The following is a description of a gene set: studied in species Mus musculus Cytokines mediate cell-cell communication in the immune system and represent important therapeutic targets. A myriad of studies have highlighted their central role in immune function, yet we lack a global view of the cellular responses of each immune cell type to each cytokine. To address this gap, the authors created the Immune Dictionary, a compendium of single-cell transcriptomic profiles of more than 17 immune cell types in response to each of 86 cytokines (>1,400 cytokine-cell type combinations) in mouse lymph nodes in vivo. A cytokine-centric view of the dictionary revealed that most cytokines induce highly cell-type-specific responses. For example, the inflammatory cytokine interleukin-1β induces distinct gene programmes in almost every cell type. A cell-type-centric view of the dictionary identified more than 66 cytokine-driven cellular polarization states across immune cell types, including previously uncharacterized states such as an interleukin-18-induced polyfunctional natural killer cell state. from publication Cui A, Huang T, Li S, Ma A, Pérez JL, Sander C, Keskin DB, Wu CJ, Fraenkel E, Hacohen N (PMID 38057668) Genes positively differentially expressed in cell type: CD8+ T cell upon treatment with cytokine: IL-4 in mouse lymph nodes in vivo. Mouse Gene Set: CUI_T_CELL_CD8_IL4_RESPONSE_UP, and this is the list of marker genes: Phb1 (NCBI Gene Id 18673), Hnrnpu, Gadd45gip1 (growth arrest and DNA-damage-inducible, gamma interacting protein 1), Ddx21, Abcf1, Fkbp4, Eif1a, H2-DMa, Ybx3, Sdad1, Uqcrb, Psma2, Hdgf, Hspe1, Adh5, St6galnac4, Esf1, Nolc1, Ifrd2, Ndufab1, Mrpl42, Pum3, Ncl, Nhp2, Mrps18b, Fam162a, Eprs1 (NCBI Gene Id 96892), Pfn1 (NCBI Gene Id 18643), Anp32b, Bzw2, Cnbp, Rsl1d1, Arid5a, Gars1, Adk, Hspa9, Slc25a5, Hspbp1, Ssb, Myc, Mia2, Gnl3, Mif, Eif3j1, Them6, Lyar, Cox7b, Tkt, Nop56, H2az1, Mrps28, Psme2, Mdn1, Ruvbl2, Rexo2, Pdap1, Ncoa7, Fubp1, Cst7, Cacybp, Nifk, Rbmxl1, Mrpl36, Gart, Prdx1, Lsm4, Foxn3, Pop5, Uqcc5, Taf10, Tmem147, Cct3, Znrd2, Cyth1, Znhit6, Slc29a1, Rnf19b, Sec11c, Impdh2 (inosine monophosphate dehydrogenase 2), Ncoa3, Ppa1, Cct5, Clic4, Tpi1, Slfn1, Syncrip, Prpf31, Tmie, Pfdn6, Atp5mc1, Ifi47, S100a13, Phgdh (NCBI Gene Id 50895), Mphosph10, Psmb10, Ybx1, Atp5f1b, Mrpl20, Mrpl51, Wdr83os, Lsm12, Glrx5, Timm10, Lap3 (leucine aminopeptidase 3), Aldh18a1, Psmc5, Rcc2, Timm13, Eif4a1, Mrpl15, Phb2, Mdh2, Utp18, Mettl1, Rrp9, Mrpl57, Npm3, Ndufs6, Nars1, Rmi2, Snhg6, Mrpl12, Dusp10, Atad3a, Ndufb4, Erh, Gtpbp4, Ppat, Snrpd1, Aimp2, Park7, Slc7a1, Elf1, Sco2, Hnrnpd, Ppan, Alkbh1, Mrps14, Tcp1, Cdk6, Snrpa, Hmgb1, Hsp90ab1, Elob, Ak2, Stat4, Ltv1, Rras2, Eif3a, Tomm40, Ppp3cc, Bcl2, Wdr43, Atp5mk, Nop14, Cdca7l, Nudc, Serbp1, Otulin, Plac8, Mybbp1a, Mbd2, Ddx18, Chchd1, Lars1, Apex1, Zfp593, Ggact, Psat1, Ifi35, Hnrnpab, Exosc8, Banf1, Ftsj3, Ldha, Psma7, Grwd1, Lsm8, Rpf2, Wdr12, Uqcr10, Oxct1, Shmt2, Dnaja2, Hsd11b1 (hydroxysteroid 11-beta dehydrogenase 1), Pa2g4, Snu13, Cycs, Rwdd1, Ndufa12, Hnrnpr, Npm1, Cct2, Pebp1, Erap1, Il4ra, Hsp90aa1, Tma16, Lsm6, Pla2g12a, Mrps24, Gpatch4 (NCBI Gene Id 66614), Atp5mc3, Bysl, Cxcr6, Polr2f, Cyc1, Cnp, Eef1e1, Uqcrq, Psmb5, Tcof1, Mri1, Mthfd1, Nip7, Lyst (lysosomal trafficking regulator), Ssrp1, Cyfip2, Jaml, Pfkp, Arpp19, Galk1, Sars1, Timm50, Gzma (NCBI Gene Id 14938), Yars1, Als2cl, Cox17, Snrpa1, Ppp1r14b, Nme1, Cd8a, Tuba1b, Eif4ebp1, Socs1, Vdac2, Agfg1, Ddx27, Dkc1, Eif1ax, Srsf2, Srm, Ndufs4, Slco3a1, Psmg4, Polr2h, Eif2s2, Cct7, Hs6st1, Bst2, Npepl1, Tspan9, Txn1, Aprt, Uqcc2, Set, Tomm5, Hspa4, Aatf, Cdca7, Lsm7, Qdpr, Txn2, Mrpl19, Ruvbl1, Timm8a1, Ndufb7, Psme1, Ptma, Eif2s1, Tuba4a, Snrpb, Llph, Pole4, Suz12, Polr1g, Glipr2, Eif5a, Tpm3, Ndufa5, Mars1, Noc2l, Xbp1, G3bp1, Nop58, Vars1, Timm10b, Pfdn2, Ran, Hspa5, Ranbp1, Mak16, Tomm20, Dnajc2, Fabp5, Fbl, Ddx39a, Nop2, Snrpf, Iars1, Gapdh, Cct8, Atic, Vapa, Emc6, Nubp1, Aars1, Eomes, Nsun2, Rgs1, Cdk4, Denr, Nptn, Ucp2, Eif4a3, Cox5a, Inpp4b, Eif3c, Hspd1, Cox6a1, U2af1, Mrpl17, Ebna1bp2, Ndufaf4, Suclg2, Eif3i, Prmt1, Nucks1, Wdr46, Smc1a, Bcl11b, Pcbp1, Timm9, Surf2, Mrpl23, Rars1, Atf4, Nefh, Jund, Bcap29, Lsm2, Ubl3, Mat2a, Dnajc7, Tars1, Pdcd4, Hnrnpf, Gar1, C1qbp, Eif1, Mthfd2, Rrp1, Uchl3, Uqcr11, Slc39a6, Srsf7, Rad23a, Rrp15, Larp1, Rrs1, Cenpx, Mettl22, Prps1, Eno1, Dctpp1, Mrto4, Cfl1, Cars1, Bax